Given this list of marker genes CITED1, MED1, CITED2, SPON1, RXRA, PPARG, PROX1, here is a description of the gene set: studied in species Homo sapiens Human Gene Set: GOMF_LBD_DOMAIN_BINDING Binding to a protein's ligand binding domain (LBD) domain, found in nuclear receptors. In general, the LBDs consist of three layers comprised of twelve alpha-helices and several beta-strands that are organized around a lipophilic ligand-binding pocket.